Given this list of marker genes Nop58, Nop56, Nolc1, Fbl, Fbll1, Snu13, Rrp9, here is a description of the gene set: Mouse Gene Set: GOCC_BOX_C_D_RNP_COMPLEX species: Mus musculus A ribonucleoprotein complex consisting of a box C/D type snRNA and three (Archaea) or four (Eukaryotes) core proteins that have diverse functions, including site-specific methylation of rRNA and processing rRNA.